The following is a description of a gene set: Mouse Gene Set: GOBP_LATE_ENDOSOME_TO_VACUOLE_TRANSPORT_VIA_MULTIVESICULAR_BODY_SORTING_PATHWAY studied in species Mus musculus The directed movement of substances from endosomes to vacuoles by a pathway in which molecules are sorted into multivesicular bodies, which then fuse with the vacuole., and this is the list of marker genes: Vps25, Chmp5, Chmp7, Ptpn23, Vps36, Snf8, Vps28, Tmem50b, Stam, Vta1, Chmp4b, Chmp6, Chmp4c, Tmem50a, Leprotl1, Leprot